Given this list of marker genes Rock1 (NCBI Gene Id 68785), App, Lrp1, Myocd, Ifngr1, Cyp51 (NCBI Gene Id 13121), Il4, Abca7, Ttpa (NCBI Gene Id 50500), Clu, Trem2, Srf, Hmgcr, Pla2g3, Ifng, Tnf, Lrpap1, Apoe, here is a description of the gene set: studied in species Mus musculus Mouse Gene Set: GOBP_REGULATION_OF_AMYLOID_BETA_CLEARANCE Any process that modulates the frequency, rate or extent of amyloid-beta clearance.